Given this list of marker genes NR4A2, FOS, TNFAIP3, CXCR4, H1-4, BTG2, JUNB, DUSP2, ZFP36, DNAJB1, here is a description of the gene set: Genes downregulated in CD4 T-cells from Idiopathic Pulmonary Fibrosis Patients vs. Controls from publication Unterman A, Zhao AY, Neumark N, Schupp JC, Ahangari F, Cosme C Jr, Sharma P, Flint J, Stein Y, Ryu C, Ishikawa G, Sumida TS, Gomez JL, Herazo-Maya JD, Dela Cruz CS, Herzog EL, Kaminski N (PMID 38717443) Thirty-eight PBMC samples from 25 patients with IPF and 13 matched controls yielded 149,564 cells that segregated into 23 subpopulations. Classical monocytes were increased in progressive and stable IPF compared to controls (32.1%, 25.2%, 17.9%, respectively, p<0.05). Total lymphocytes were decreased in IPF vs controls, and in progressive vs stable IPF (52.6% vs 62.6%, p=0.035). Tregs were increased in progressive vs stable IPF (1.8% vs 1.1% of all PBMC, p=0.007), although not different than controls, and may be associated with decreased survival (P=0.009 in Kaplan-Meier analysis; P=0.069 after adjusting for age, sex, and baseline FVC). Flow cytometry analysis confirmed this finding in an independent cohort of IPF patients. Fraction of Tregs out of all T cells was also increased in two cohorts of lung scRNA-seq. CCL22 and CCL18, ligands for CCR4 and CCR8 Treg chemotaxis receptors, were increased in IPF. The single-cell atlas of the peripheral immune system in IPF, reveals an outcome-predictive increase in classical monocytes and Tregs, as well as evidence for a lung-blood immune recruitment axis involving CCL7 (for classical monocytes) and CCL18/CCL22 (for Tregs). (From Abstract) Human Gene Set: UNTERMAN_IPF_VS_CTRL_CD4T_DN species: Homo sapiens